The following is a description of a gene set: Loss of consciousness Loss of alertness and orientation to place and time. species: Homo sapiens Human Gene Set: HP_LOSS_OF_CONSCIOUSNESS, and this is the list of marker genes: TRAF3, GK, MTRR, STAT6, TBK1, GCDH, KCNJ11, UCP2, KCNE1, CPT1A, RNU4ATAC, ADORA2A, KCNQ1, ABCC8, HNF1A, NAGS, UPB1, NOTCH3, GLYCTK, TICAM1, UNC93B1, ACADM, SLC19A3, MT-CYB, NOTCH2NLC, TLR3, NAB2